The following is a description of a gene set: part of: Asparagine N-linked glycosylation species: Mus musculus This event has been computationally inferred from an event that has been demonstrated in another species.<p>The inference is based on the homology mapping from PANTHER. Briefly, reactions for which all involved PhysicalEntities (in input, output and catalyst) have a mapped orthologue/paralogue (for complexes at least 75% of components must have a mapping) are inferred to the other species. Reactome Pathway: Transport to the Golgi and subsequent modification electronically inferred by orthology from the curated human pathway, and this is the list of marker genes: Tuba3b, Tgfa, Cog7, Gorasp1, Golga2, Rab1b, Kdelr3, Chst8, Ctsc, Mgat1, Kdelr1, Tubb4a (NCBI Gene Id 22153), Tuba1b, Cga, Arf5, Cnih2, Col7a1, Cog8, Tuba1a, Kdelr2, Mgat4c (NCBI Gene Id 67569), Sec24d, Sec24b, Fut8, Tubb2b, Copg1, Arfgap2, Rab1a (NCBI Gene Id 19324), Arcn1 (archain 1), Tuba1c, Cnih3, Tubb6, Lman1l, Man2a1, B4galt6, Trappc5, Actr1a, Copb2, Scfd1, Dctn1, Uso1, Arf1, Bet1 (NCBI Gene Id 12068), Cd55, Sec31b (NCBI Gene Id 240667), F8, Tuba8, Tmed9, Tmed3, Folr1, St3gal4, Ank1, Lman2l, Man1a, Ppp6c, St8sia3, Tuba4a, Actr10, Man1c1, Copg2, Sec31a, Areg, Sptbn2, Ins2, Trappc9, Tubb4b, Ins1, Nsf, Sec16b, Sec24a, Dync1li2 (NCBI Gene Id 234663), Dctn6, Tmed10, Sptbn4 (NCBI Gene Id 80297), Tubal3, Dynll1, Lman1, Manea, St8sia2, Copb1